Given this list of marker genes YES1, FCER1G, CD200R1, MAP2K4, FER, TRAF6, FCGR3B, FCGR1BP, PRKCQ, PLA2G6, PLCG1, PRKCE, MAP2K7, LCK, FCGR2A, FCAR, VAV1, MAPK10, SRC, PLD2, PLCG2, SOS1, LIMK1, PAK1, PTK2, NOS2, MYO1G, NR4A3, FCMR, IFNG, PRKCD, CD247, KIT, PIGR, FYN, FCGR1A, MAPK9, LILRA4, FCER2, IKBKB, MAPK8, MAP3K1, BTK, CLEC4E, APPL2, FCGR3A, VAV3, PLPP4, CD33, FCGR2B, APPL1, HCK, ABL1, MAP3K7, FGR, VAV2, FCGR2C, CLEC4D, FCER1A, LYN, SYK, here is a description of the gene set: The series of molecular signals initiated by the binding of the Fc portion of an immunoglobulin to an Fc receptor on the surface of a target cell, and ending with the regulation of a downstream cellular process, e.g. transcription. The Fc portion of an immunoglobulin is its C-terminal constant region. Human Gene Set: GOBP_FC_RECEPTOR_SIGNALING_PATHWAY species: Homo sapiens